The following is a description of a gene set: Human Gene Set: GOBP_FIBROBLAST_MIGRATION Cell migration that is accomplished by extension and retraction of a fibroblast pseudopodium. A fibroblast is a connective tissue cell which secretes an extracellular matrix rich in collagen and other macromolecules. studied in species Homo sapiens, and this is the list of marker genes: TGFB1, HAS1, FGF2, MIR19B1, FER, SGPL1, ARID5B, WDPCP, ACTA2, HYAL2, ILK, PRR5L, FAM114A1, ITGB1, IQGAP1, GNA13, BAG4, MIR145, CCN3, RFFL, TMEM201 (transmembrane protein 201), MIR19A, AQP1, CORO1C, ARHGAP4, PLEC, CD248, RCC2, PAK1, THBS1, GNA12, LAMTOR2, AKT1, ZFAND5, AKAP12, BRAF, PIP5K1A, NHERF1, SDC4, MACIR, APPL1, CLN3, PTK2, PRKCE, DMTN, ITGB3, MTA2, APPL2, DDR2, CYGB, RAC1, ZEB2, PML, PDLIM1, TNS1, ITGB1BP1, ARHGEF7, FUT8